Given this list of marker genes PIP4K2C, IL18R1, PSMB9, GALNT11, CD8A, MID1IP1, NDUFB3, GCLM, ZMYM6, AREL1, C2orf42, MTCH2, PSMD7, PLSCR1, NPRL2, NME6, CDC42EP3, MRPS31, PMS1, MGAT2, SPATA7, RAD51B, MICAL2, CD96, MKNK1, TRGV5, SPOP, KLRC4, DYNLT3, ARPP19, APOBEC3C, PLAAT4, PNP, TRIM32, PARP8, PGM1, EHBP1, DFFA, GAS1, PRKCH, ATP6V0A2, SH2D1A, GLS, PEX13, GBP1, OGFOD1, TNFRSF1A, TMEM9B, DKC1, LYRM2 (NCBI Gene Id 57226), UCHL5, PARK7, FECH, CDKL3, SEPTIN7, DIABLO, PIGV, TARS2, CAB39, UTP14C, DAXX, RNF170, GPR171, SLC4A1AP, ZNF304, TPK1, CRTAM, ABCF2, KLHL9, SUPT16H, DARS1, RPA2, DIMT1, RAB22A, ICE1, GLT8D1, CD8B, SLC25A44, EXOC2, CHSY1, DENND4C, PCCA, RALBP1, EMG1, TNFSF14, PTCH1, RAPGEF6, TRAF5, GABPB1, ZNF443, NEK7, SEL1L3, MED8, PARP1, YBX3, TSEN34, INTS14 (NCBI Gene Id 81556), TPT1P8, MECP2, NCK1, TM2D1, SLC44A4, CD3D, SLC39A14, ARHGAP25, ANKMY2, C1orf174, RRAS2, ADAT1 (adenosine deaminase tRNA specific 1), INVS, EOLA2, DPP8, FAM114A2, PDCD10, ARL1 (ADP ribosylation factor like GTPase 1), PDCD6, LRCH3, SYTL2, SLC25A20, ISOC1, TMEM186, USP11, HIGD1A, ZMPSTE24, NDUFAF1, CRKL, PRR5, SNAPC5, TSPAN32, TBC1D10B, SYNRG, WDR5B, TMA16, SDAD1, PSMA5, TXNDC9, SEC11A, CBLB, APTX, MMUT, ZFAND6, GTF2E1, GABARAPL2, SELENOP, HMCES, ALG5, ARL6IP1, CARS1, NAA38, ATR, NAA40, H4C3, NCALD, TM9SF1 (NCBI Gene Id 10548), POP4 (NCBI Gene Id 10775), ATP8A1, SDF2, UBE2K, STX6, ZNF232, NEK4, LAX1, TRAPPC2, CKLF, ABCF1, RPS6KA3, RARS1 (NCBI Gene Id 84715), ORMDL2, KMT5B, NME7, RDX, TMCO1, TARP, LRIF1, GGPS1, TMEM156, RFK, GPN1, HTRA2, CISH, TPM1, ZNF816, HPS5, WDR7, LPXN, GGNBP2, DPY19L4, CCR5, ABCA11P, PVRIG, SCCPDH, DKK3, KIAA0232, SLC26A2, GTDC1, MNAT1 (NCBI Gene Id 4331), ERGIC2, DNAL4, VPS26C, TLR3, here is a description of the gene set: from publication Abbas AR, Baldwin D, Ma Y, Ouyang W, Gurney A, Martin F, Fong S, van Lookeren Campagne M, Godowski P, Williams PM, Chan AC, Clark HF (PMID 15789058) Immune cell-specific expression is one indication of the importance of a gene's role in the immune response. In order to identify such patterns, we set out to broadly profile gene expression in a variety of immune cells. species: Homo sapiens Genes up-regulated in comparison of naive CD8 T cells versus naive CD4 T cells. Human Gene Set: GSE22886_CD8_VS_CD4_NAIVE_TCELL_UP